The following is a description of a gene set: Mouse Gene Set: GOBP_REGULATION_OF_VOLTAGE_GATED_CALCIUM_CHANNEL_ACTIVITY studied in species Mus musculus Any process that modulates the frequency, rate or extent of voltage-gated calcium channel activity., and this is the list of marker genes: Drd4, Cacnb4, Sri, Cacnb2, Gpr35, Cbarp, Stac, Stac2, Ahnak, Stac3, Dysf, Calm1, Ehd3, Gnb5, Dmd, Calm3, Fgf14, Cacna1f, Drd2, Cacnb3, Fmr1, Nipsnap2, Hpca